Given this list of marker genes BAX, MED1, B4GALT1, STAT5B, LHCGR, STAT5A, TGFB1, IRF2BPL, WNT5A, AREG, PHB2, here is a description of the gene set: The process whose specific outcome is the progression of the secondary sexual characteristics over time, from their formation to the mature structures. In humans, these include growth of axillary, chest, and pubic hair, voice changes, testicular/penile enlargement, breast development and menstrual periods. Development occurs in response to sex hormone secretion. Human Gene Set: GOBP_DEVELOPMENT_OF_SECONDARY_SEXUAL_CHARACTERISTICS studied in species Homo sapiens